Given this list of marker genes STEAP2, GLRA2, ITIH3, CACHD1, GLRA1, SLC8A3, VAT1L, GABRQ, NSMAF, EBF3 (EBF transcription factor 3), MTMR2, CD83, P2RX5, HJURP, PCOLCE2, SLC17A6, TTC39A, PTGDS, TCF7L2, KCTD9, EPHB1, SLC7A3, OPALIN, EN1, SEMA4G, GLRA4, CLGN, PLP1, HMGA1, CREBL2, AGTR2, PRPH, GJE1, PCSK1N, CERS2, LTBP3, ANKRD55, DNM3, ALDOC, KIAA0930, KLHL1, MAGED2, COPRS, HARS2, PANX2, DLK1, QDPR, GPC5, ARRDC1, FAM156A, SEMA3F, PHLDA3, BCAT1, UBLCP1, KANK4, AGT, AMIGO2, CARMIL3, BAIAP3, PIGT, HTR2C, ARHGEF40, HAP1, SLC6A3, BNC2, TRAIP, SLC39A14, COL15A1, ZFHX4, ECE2, DDC, GLRA3, POU4F1, ITGA10, CMKLR2 (NCBI Gene Id 2825), DENND1B, ENDOD1, AFAP1, GFRA1, ZFHX3, TSC22D3, EIF5A2, SLC4A2, here is a description of the gene set: species: Mus musculus from publication Lein ES, Hawrylycz MJ, Ao N, Ayres M, Bensinger A, Bernard A, Boe AF, Boguski MS, Brockway KS, Byrnes EJ, Chen L, Chen L, Chen TM, Chin MC, Chong J, Crook BE, Czaplinska A, Dang CN, Datta S, Dee NR, Desaki AL, Desta T, Diep E, Dolbeare TA, Donelan MJ, Dong HW, Dougherty JG, Duncan BJ, Ebbert AJ, Eichele G, Estin LK, Faber C, Facer BA, Fields R, Fischer SR, Fliss TP, Frensley C, Gates SN, Glattfelder KJ, Halverson KR, Hart MR, Hohmann JG, Howell MP, Jeung DP, Johnson RA, Karr PT, Kawal R, Kidney JM, Knapik RH, Kuan CL, Lake JH, Laramee AR, Larsen KD, Lau C, Lemon TA, Liang AJ, Liu Y, Luong LT, Michaels J, Morgan JJ, Morgan RJ, Mortrud MT, Mosqueda NF, Ng LL, Ng R, Orta GJ, Overly CC, Pak TH, Parry SE, Pathak SD, Pearson OC, Puchalski RB, Riley ZL, Rockett HR, Rowland SA, Royall JJ, Ruiz MJ, Sarno NR, Schaffnit K, Shapovalova NV, Sivisay T, Slaughterbeck CR, Smith SC, Smith KA, Smith BI, Sodt AJ, Stewart NN, Stumpf KR, Sunkin SM, Sutram M, Tam A, Teemer CD, Thaller C, Thompson CL, Varnam LR, Visel A, Whitlock RM, Wohnoutka PE, Wolkey CK, Wong VY, Wood M, Yaylaoglu MB, Young RC, Youngstrom BL, Yuan XF, Zhang B, Zwingman TA, Jones AR (PMID 17151600) Top 100 ranked genes most specific to midbrain region of adult mouse brain. Molecular approaches to understanding the functional circuitry of the nervous system promise new insights into the relationship between genes, brain and behaviour. The cellular diversity of the brain necessitates a cellular resolution approach towards understanding the functional genomics of the nervous system. We describe here an anatomically comprehensive digital atlas containing the expression patterns of approximately genes in the adult mouse brain. Data were generated using automated high-throughput procedures for in situ hybridization and data acquisition, and are publicly accessible online. Newly developed image-based informatics tools allow global genome-scale structural analysis and cross-correlation, as well as identification of regionally enriched genes. Unbiased fine-resolution analysis has identified highly specific cellular markers as well as extensive evidence of cellular heterogeneity not evident in classical neuroanatomical atlases. This highly standardized atlas provides an open, primary data resource for a wide variety of further studies concerning brain organization and function. Human Gene Set: LEIN_MIDBRAIN_MARKERS